Given this list of marker genes CRK, GGA3, RAB4B, GAB1 (GRB2 associated binding protein 1), ARF6, CRKL (CRK like proto-oncogene, adaptor protein), HGF, RAB4A, MET, GRB2, here is a description of the gene set: MET receptor recycling studied in species Homo sapiens Human Gene Set: REACTOME_MET_RECEPTOR_RECYCLING